The following is a description of a gene set: Human Gene Set: GOBP_NK_T_CELL_PROLIFERATION species: Homo sapiens The expansion of a NK T cell population by cell division., and this is the list of marker genes: IL15 (NCBI Gene Id 3600), ZBTB7B, JAK2, IL18, IL23A, IL12B, MYC, TYK2, ELF4, RASAL3